The following is a description of a gene set: Human Gene Set: WINZEN_DEGRADED_VIA_KHSRP from publication Winzen R, Thakur BK, Dittrich-Breiholz O, Shah M, Redich N, Dhamija S, Kracht M, Holtmann H (PMID 17908789) mRNA stability is a major determinant of inflammatory gene expression. Rapid degradation of interleukin-8 (IL-8) mRNA is imposed by a bipartite AU-rich element (ARE) in the 3' untranslated region (R. Winzen et al., Mol. Cell. Biol. 24:4835-4847, 2004). Small interfering RNA-mediated knockdown of the ARE-binding protein KSRP resulted in stabilization of IL-8 mRNA or of a beta-globin reporter mRNA containing the IL-8 ARE. Rapid deadenylation was impaired, indicating a crucial role for KSRP in this step of mRNA degradation. The two IL-8 ARE domains both contribute to interaction with KSRP, corresponding to the importance of both domains for rapid degradation. Exposure to the inflammatory cytokine IL-1 has been shown to stabilize IL-8 mRNA through p38 mitogen-activated protein (MAP) kinase and MK2. IL-1 treatment impaired the interaction of KSRP with the IL-8 ARE in a manner dependent on p38 MAP kinase but apparently independent of MK2. Instead, evidence that TTP, a target of MK2, can also destabilize the IL-8 ARE reporter mRNA is presented. In a comprehensive approach to identify mRNAs controlled by KSRP, two criteria were evaluated by microarray analysis of (i) association of mRNAs with KSRP in pulldown assays and (ii) increased amounts in KSRP knockdown cells. According to both criteria, a group of 100 mRNAs is controlled by KSRP, many of which are unstable and encode proteins involved in inflammation. These results indicate that KSRP functions as a limiting factor in inflammatory gene expression. species: Homo sapiens Transcripts (mRNA molecules) rapidly degraded upon interaction with KHSRP., and this is the list of marker genes: IL6, STK38L, ZFP36, DNAJB5, DUSP5, CAV2, B3GNT2, TFAP2C, CLDN12, PPP1R3C, SDC2, CXCL10 (NCBI Gene Id 3627), PDGFC, TRIM6, TGFBR3 (transforming growth factor beta receptor 3), IL23A, TGFA, SCG5, EREG, RNF144B, TRPC1, PTGFR, CXCL2, FST, GEM, IFIT2, CXCL3, IFIT1, CCDC68, PKIA, INHBA, MUC13, SERPINE2, DKK1, ZFAND6, ARL14, SMPDL3A, PMAIP1, BMP2, CXCL11, F11R, BDNF, ID2, GPR183, NFKBIZ (NFKB inhibitor zeta), IRS1, HAS2, LMO2 (NCBI Gene Id 8051), CPEB4, SCHIP1, ERRFI1, ELOVL4, PTHLH, TSLP, STYK1, EDN1, AMOTL2, TNF, TMC7, CSF2, SPINK1, PTGER4, NTN4, SERPINI1, FMN2, CMKLR2, CTSL, SELE, DPY19L1P1, ADRB2, YRDC, CXCL8, JAG1, NR4A2, SPRY4, F3, CYP24A1, HBEGF, PLAUR, GREM1, EDN2 (endothelin 2), SLITRK6, GDF15, CYP26B1, ANKRA2, CCN2, RHEBL1, CCL20, YPEL5, DUSP6, SDC4, FRY, SHC4, PTGS2, ITGA6, CCN1, SLC4A4, PDGFA, SPRY2, PAPPA